Given this list of marker genes CIR1, TRAPPC3, ERLIN2, TPM4, GAL, PEG10, SLITRK5, ANG (NCBI Gene Id 283), FCN1, APOE, SMR3B, OGG1, MCF2L, DNAL4, FOS, GPC1, KRT75, INSIG1, GFRA3, HSPA5, SLC6A3, HOXA5, SLC2A5, SH3BP5, SORL1, TUBGCP2, IGHA1, APOC1, F3, TECPR2, TMPRSS15, ZMIZ1, MBOAT7, ADCY3, CECR7, GUCA1B, MANF, CD52, ITGB5, BNIP3L, FCGR1A, IGFBP7, HLA-E, EGR4, NDUFB8, CD14, EMP1, RASAL2, EHHADH, CTNNA2, TPP1, LPL, SDC3, BCL7B, ABCG1, FOLR3, MACROH2A1, ALOX5, SCGB1D2, KIF5A, FCMR, PTGDS, SEMA3A, COX6B1, RND3, PTGER2, FCAR, ITGA3 (NCBI Gene Id 4454), TRIM33, SPARC, ITGA6, CNOT8, LY86, NDUFS3, GLUL, KCTD12, GZMM, CTBP2, ZMIZ2, NDRG1, TKT, GBE1, NT5E, BCL2A1, LTA4H, REPS1, RXRA, ITGB1BP1, DNASE2, CEBPD, BNIP3, DBF4, CTSK, CDC42EP1, ADARB1, VNN2, TBL2, CACNG3, EFNB2, TESK1, GNAL (NCBI Gene Id 2774), CADM1, CHIT1 (chitinase 1), SUPT7L, HR, SMPDL3A, NOL3, MERTK, S100A8, ALG3, G6PC1, CPE, EMILIN1, CDA, GDF11, ZDHHC17, BCAT1, LMNA, FOXI1, ABCB4 (NCBI Gene Id 5244), SLC6A8, SLC1A5, SPRY1, XRCC1, PLA2G15, HFE, ZNF165, SLC11A1, IDS, CD163, USF2, GSTZ1, SIK1, CALM3, FOLR2, TNFSF12, MADCAM1, GPC4, LILRA2, CRABP2, RCBTB2, CTDNEP1, PDIA4, PECAM1, TM4SF4 (NCBI Gene Id 7104), HDAC5, FOXO4, VEGFB, HTR3A, CKAP4, KCNG1 (potassium voltage-gated channel modifier subfamily G member 1), TSC22D3, VSIG4, SLC29A2, FYN, RPS6KA2, HERPUD1, MAST2, QRICH1, FGFBP1, SCG2 (secretogranin II), C3AR1, MOS (NCBI Gene Id 4342), SASH1, TGFA, LYL1, PPIH, PIP4K2B, GPNMB, CHMP2B, HABP2, AKT3, TLR5, LGALS2, TMT1A, S100A4, N4BP2L2-IT2, TIMP2, STAB1, SLC19A1, MYL6B, RUNDC3B, ARHGAP26, HTRA1, SHB, GEM, HAPLN1, DUSP6, FAM8A1, BAG5, NOTCH3, ST3GAL5, VCAN, ALDH3B1, DXO, MIOS, CD300A, ENO2, PINK1, here is a description of the gene set: studied in species Homo sapiens Human Gene Set: GSE360_DC_VS_MAC_T_GONDII_DN Monocyte-derived dendritic cells (DC) and macrophages (MΦ) generated in vitro from the same individual blood donors were exposed to five different pathogens, and gene expression profiles were assessed by microarray analysis. Responses to Mycobacterium tuberculosis and to phylogenetically distinct protozoan (Leishmania major, L. donovani, Toxoplasma gondii) and helminth (Brugia malayi) parasites were examined, each of which produces chronic infections in humans yet vary considerably in the nature of the immune responses they trigger. Genes down-regulated in comparison of dendritic cells (DC) exposed to T. gondii versus macrophages exposed to T. gondii. from publication Chaussabel D, Semnani RT, McDowell MA, Sacks D, Sher A, Nutman TB (PMID 12663451)